Given this list of marker genes Hexa (hexosaminidase A), Oga, Hexd, Chil3, Hexb, here is a description of the gene set: species: Mus musculus Catalysis of the hydrolysis of terminal non-reducing N-acetyl-D-glucosamine residues in N-acetyl-beta-D-glucosaminides. Mouse Gene Set: GOMF_BETA_N_ACETYLGLUCOSAMINIDASE_ACTIVITY